The following is a description of a gene set: Human Gene Set: HP_MALIGNANT_GASTROINTESTINAL_TRACT_TUMORS Malignant gastrointestinal tract tumors studied in species Homo sapiens, and this is the list of marker genes: MUTYH, AAGAB, FGFR3, RPS20, RPS26, BAX, RPL31, RPS29, HEATR3, RPL26, STK11, BUB1, SMAD4, TGFBR2, MAD1L1, BUB1B, MLH1, MSH2 (mutS homolog 2), RPS15A, BMPR1A, RPS17, COL14A1, PIK3CA, RPL18, TCF4, RPS19, FLCN, RPL15, EPCAM, RPL9, AURKA, TLR2, WRN, DCC, SEMA4D, DLC1, NTHL1, ADA2, NRAS, PDGFRL, EP300, MST1, CCND1, POLD1, RPL35A, GREM1, TP53, RPL27, SRC, RPS24, RPL35, RPS27, RPS10, GATA1, AKT1, PTPRJ, MCC, RPS28, POLE, RPL11, RPL5, BRAF, RPS7, MSH6, TSR2, CTNNB1, AXIN2, RPL8, GPR35, RAD54B, APC, PTPN12, MLH3, PLA2G2A, PMS2